Given this list of marker genes Fyn, Vav1, Pik3r2, Yes1, Map3k8, Ppp2r5b (protein phosphatase 2, regulatory subunit B', beta), Pdpk1, Ppp2r5a, Ctla4, Grap2 (GRB2-related adaptor protein 2), Pik3r5 (NCBI Gene Id 320207), Ppp2r5d, Rictor, Ppp2r1b, Grb2, Pak3, Cd28, Map3k14, Them4, Lck, Pik3cb, Cd80, Cdc42, here is a description of the gene set: electronically inferred by orthology from the curated human pathway Reactome Pathway: Co-stimulation by CD28 part of: Regulation of T cell activation by CD28 family studied in species Mus musculus This event has been computationally inferred from an event that has been demonstrated in another species.<p>The inference is based on the homology mapping from PANTHER. Briefly, reactions for which all involved PhysicalEntities (in input, output and catalyst) have a mapped orthologue/paralogue (for complexes at least 75% of components must have a mapping) are inferred to the other species.